The following is a description of a gene set: studied in species Homo sapiens During acute viral infections, naïve CD8+ T cells differentiate into effector CD8+ T cells and, after viral control, into memory CD8+ T cells. Memory CD8+ T cells are highly functional, proliferate rapidly upon reinfection and persist long-term without antigen. In contrast, during chronic infections, CD8+ T cells become “exhausted” and have poor effector function, express multiple inhibitory receptors, possess low proliferative capacity, and cannot persist without antigen. To compare the development of functional memory T cells with poorly functional exhausted T cells, we generated longitudinal transcriptional profiles for each. Genes down-regulated in CD8 T cells at day 30: memory cells after acute infection with LCMV-Armstrong versus exhausted cells during chronic infection with LCMV-Clone 13. from publication Doering TA, Crawford A, Angelosanto JM, Paley MA, Ziegler CG, Wherry EJ (PMID 23159438) Human Gene Set: GSE41867_MEMORY_VS_EXHAUSTED_CD8_TCELL_DAY30_LCMV_DN, and this is the list of marker genes: NLRP6, CASP3, MCFD2, SOX13, CD48, CPNE3, DCAF6, TM2D3 (TM2 domain containing 3), SBF2, MEGF8, BDP1, MYDGF, HACD2, CLINT1, SPCS3, DRAM2, TXLNG, CD81, TRAM1, ATP8B2, SMAD4, PABIR1, KRTCAP2, SELENOF, CMAS, RDH10, ETHE1, ZNF148, PDIA6, PRDX4, TMEM52, MPC2, ZKSCAN1, ALDOC, RAI1, ACOX1, ERLEC1, RIPPLY3, IL18, DCAF12, HM13, OAT, ADD1, UAP1, TSPAN13, DYRK3, GRIN2A, ST14, PBK, WDR27, HNRNPLL, ITFG1, TCEAL9, NDUFA1, CACNG8, UBN1, ARMCX2, CIMIP5 (ciliary microtubule inner protein 5), PRDX2, ECI2, SEPSECS, TMEM167A, PPP1R15A, MYLK, TMEM25, RAB3D, MCCC2, TNS3, DCUN1D4, CGRRF1, MRPL57, CLPTM1L, MYADM, IDH2, KDELR1, MBTPS1, FKBP11, IL13RA1, DNPEP, GARRE1, TMEM165, USP22, INTS6L, HADHB, PPP1R15B, ATF6, SYNRG, NARF, ERP44, P2RX4, ICA1, STAT5B, IRF4, DHDDS, ARFGAP3, ACTR8, ABCB11, SEC23B, SLC44A1, MRPS14, DKKL1, BPGM, IGF1R, KIFC2, CA2 (carbonic anhydrase 2), ETV5, SAA4, DNASE2, SRSF9, PANK3, TRABD, GNPNAT1, JTB, ZSCAN21, TMBIM4, GSTT1, UBE2A, HEXIM2, PEX2, APLP2, PGRMC1, CDK2AP2, PRRC2A, LHPP, ZCWPW2, FUOM, PHYHD1, DGKA, PDIA4, PON3, FER, EDEM1, PRR3, TRAPPC2B, GNAQ, CALU, SPCS1, TM2D1, SPINT2, RTN4RL1, CPD, DPY19L3, YAE1, TNFRSF17, CABP4, ANXA5, EIF2AK3, S100PBP (S100P binding protein), CKAP4, INS, CRADD, STX5, REXO2, JADE1, MAN2A1, CDC42SE2, IL6R, TMEM182, MAGED1, SKIL, MVB12A, CREB3L2, CRIP1 (NCBI Gene Id 1396), VCL, MTOR, GKAP1, TMED10, FBXO2, RAP1A, RASL12, IKZF3, AGFG2, SNX21, CREG1 (cellular repressor of E1A stimulated genes 1), ACADSB (NCBI Gene Id 654185), HMOX2, CFI, ARFIP2, NDFIP1, OSBP, ZNF496 (zinc finger protein 496), SSR4, IFT80, SMAD5, RELN, MGAT1, GALNT2, TEX14, CCDC141, EPCAM, LPCAT3, PGK1, IL10RB, CAPN2, UGDH, TXNDC5, TMEM150A, ECHDC1, CCDC88A, CD2BP2